The following is a description of a gene set: Mouse Gene Set: MIR_7090_3P species: Mus musculus from publication Chen Y, Wang X (PMID 31504780) Genes predicted to be targets of miRBase v22 microRNA mmu_miR_7090_3p in miRDB v6.0 with MirTarget v4 prediction scores > 80 (high confidence targets)., and this is the list of marker genes: Snrnp27, Zfp748, Cldn1, Zfx (NCBI Gene Id 22766), Mettl21e, Zfp874b, Zfp947, Zfp874a, Pira12, Itgav, Psmd14, Sp4, Zfp607b, Nudt4, Dipk2a, Gucy1a2, Acot3, Hsf2, Glipr1l2, Cyp2j6, Tnrc6b, Dcaf12l1 (NCBI Gene Id 245404), Psme4, Ankrd28, Tmem9, Gabra1, Dynlt3, Pira2 (paired-Ig-like receptor A2), Zfp60 (NCBI Gene Id 76165), Zfp652, Eif2s1, Ankrd6, Dazap2, Nsa2, Zmym2, Tex16, Mms19 (NCBI Gene Id 98164), Vwc2, Surf4 (NCBI Gene Id 99162), Fam210b, Epha4, Cstpp1, Lats2, Unc5c, Htr7, Kctd3, Zfp930, Zfp820, Xk, Glud1, Ildr2, Zfp39, Cdc14b, Phyhipl, Mip, Sh3rf3, Zfp995, Cetn3, Cks1brt (CDC28 protein kinase 1b, retrogene), Zfp994, Nkain3, Braf (Braf transforming gene), Xpnpep3, Cdh11, Pitpnb, Mbnl1, Mycbp2, Ybx2, Hacd2, Trp53inp2, Ube2d3, Nat3, Homer3, Nemf, Satl1, Rsbn1l, Tmem178b, Oosp2, Itga4, Psd3, Gbp10, St13, Pyurf, Scn1a, Pdgfa, Ndfip2, Syn3, Pde6a, Usp49, Tex9, Efcab5, Zeb2, Ncapg2, Cacna2d1, Sorcs3, Camk4, Kcnv1, Erc2, Taf3, Arpp21, Prss35, Zfp780b, Gabrb2 (NCBI Gene Id 78533), D630023F18Rik, Nvl, Krtap9-20 (NCBI Gene Id 100415785), Kpna4, Kdm5b, Arrdc3, Elf4, Mc3r, Usp13, 4930402K13Rik, Fut9, Pex3, Aplp2, Il17rd, Tenm3, Acp1, Atrx